The following is a description of a gene set: species: Homo sapiens Human Gene Set: MIR524_3P_MIR525_3P Genes predicted to be targets of miRBase v22 microRNA hsa-miR-524-3p, hsa-miR-525-3p in miRDB v6.0 with MirTarget v4 prediction scores > 80 (high confidence targets). from publication Chen Y, Wang X (PMID 31504780), and this is the list of marker genes: ACTB, EDC3, KCNA5, ZFPM2, SH3BGR, SACM1L, BICC1, KPNB1 (karyopherin subunit beta 1), SIRT3 (NCBI Gene Id 23410), EBF1, GET1-SH3BGR, SEPTIN4, CSDE1